Given this list of marker genes RACGAP1, DNAJC10, CETN2, MPHOSPH9, PARD3, RBM41, RPL10A, ZNF652, SH3GLB2, CUL4B (NCBI Gene Id 8450), SMURF2, PABIR2, R3HDM1, SYNGR2, ZBTB38, SKA2, USH1C, KCNK1 (potassium two pore domain channel subfamily K member 1), SSR3, PTPN11, here is a description of the gene set: from publication Wang SM, Ooi LL, Hui KM (PMID 17975138) Human Gene Set: WANG_RECURRENT_LIVER_CANCER_UP Genes up-regulated in samples from patients with recurrent hepatocellular carcinoma (HCC). species: Homo sapiens PURPOSE: To improve the clinical management of human hepatocellular carcinoma (HCC) by accurate identification, at diagnosis, of patients at risk of recurrence after primary treatment for HCC. EXPERIMENTAL DESIGN: Two clinicopathologic variables available at diagnosis, vascular invasion and cirrhosis, together with molecular profiling using Affymetrix human HG-U133A and HG-U133B oligonucleotide probe arrays, were used to identify recurrent HCC disease. RESULTS: HCC patients presented clinically at diagnosis with vascular invasion and cirrhosis showed a high rate (78-83%) of developing recurrent disease within 6 to 35 months. In comparison, most of the HCC patients (80-100%) without vascular invasion and cirrhosis remained disease-free. However, the risk of recurrent disease for HCC patients with either vascular invasion or cirrhosis could not be accurately ascertained. Using a pool of 23 HCC patients with either vascular invasion or cirrhosis as training set, a 57-gene signature was derived and could predict recurrent disease at diagnosis, with 84% (sensitivity 86%, specificity 82%) accuracy, for a totally independent test set of 25 HCC patients with either vascular invasion or cirrhosis. On further analysis, the disease-free rate was significantly different between patients that were predicted to recur or not to recur in the test group (P = 0.002). CONCLUSION: We have presented data to show that by incorporating the status of vascular invasion and cirrhosis available at diagnosis for patients with HCC after partial curative hepatectomy and a novel 57-member gene signature, we could accurately stratify HCC patients with different risks of recurrence.